The following is a description of a gene set: part of: Defective Base Excision Repair Associated with NTHL1 studied in species Homo sapiens NTHL1 D239Y is produced as a consequence of a single nucleotide polymorphism (SNP) rs3087468 in the NTHL1 gene. The frequency of this polymorphism varies in different populations. Substitution of aspartic acid residue at position 239 with tyrosine results in an NTHL1 protein that is still able to bind to damaged DNA but appears to have impaired glycosylase activity. Expression of NTHL1 D239Y in non-transformed human and mouse mammary epithelial cells increases genomic instability and leads to neoplastic transformation, acting as a dominant negative for wild-type NTHL1, through competition for substrate binding. It is uncertain if heterozygosity for NTHL1 D239Y polymorphism increases predisposition to cancer. Reactome Pathway: Defective NTHL1 substrate processing, and this is the list of marker genes: NTHL1